Given this list of marker genes CHRNE, SYT2, AGRN, CHRND, DOK7, SLC25A1, MUSK, COLQ, SLC18A3, CHRNB1, ALG14, RAPSN, PLEC, SCN4A, CHRNA1, VAMP1, PREPL, COL13A1, MYO9A, SLC5A7, CHAT, SNAP25, here is a description of the gene set: Anti-acetylcholine receptor antibody positivity The presence of autoantibodies (immunoglobulins) in the blood circulation that react against acetylcholine receptor. Human Gene Set: HP_ANTI_ACETYLCHOLINE_RECEPTOR_ANTIBODY_POSITIVITY species: Homo sapiens